Given this list of marker genes Rps27a, Pfn2, Dag1, Pfn1, Evl, Cxcl12, Ubb, Vasp (NCBI Gene Id 22323), Cxcr4, here is a description of the gene set: Reactome Pathway: Signaling by ROBO receptors This event has been computationally inferred from an event that has been demonstrated in another species.<p>The inference is based on the homology mapping from PANTHER. Briefly, reactions for which all involved PhysicalEntities (in input, output and catalyst) have a mapped orthologue/paralogue (for complexes at least 75% of components must have a mapping) are inferred to the other species. part of: Axon guidance electronically inferred by orthology from the curated human pathway species: Mus musculus